The following is a description of a gene set: Human Gene Set: FAN_EMBRYONIC_CTX_BRAIN_ENDOTHELIAL_2 from publication Fan X, Dong J, Zhong S, Wei Y, Wu Q, Yan L, Yong J, Sun L, Wang X, Zhao Y, Wang W, Yan J, Wang X, Qiao J, Tang F (PMID 29867213) studied in species Homo sapiens, and this is the list of marker genes: BCHE, PGF, CCDC80, COL9A1, CCDC3, TJP1, PTH1R, FOXF2, C12orf57, GNG11, HEY2, PDLIM2, PARD3, ITPR1, ECM2, FBLN1, TFPI, CPE (carboxypeptidase E), EFEMP2, SLC12A2, TNFRSF21, TBX2, DCN, SEPTIN4, SLC20A2, SPARC, SGPL1, TAGLN2, GRM3, GALNT18, NR2F2, CDC42BPA (NCBI Gene Id 9876), PDE8B (NCBI Gene Id 8622, phosphodiesterase 8B), ANXA2, ADGRD1, PDLIM1, DGKH, LHFPL6, PTPRK, SEMA5A, SPRY1, KCNE4, CYTOR, CYTH3, SMTN, CNN3, TCEAL9, LGALS1, COX7A1, COL1A2, LURAP1L, ITIH5, PPFIBP2, ST3GAL5, AKAP12, F2R, ADORA2B, DMD, PCDH18, CAVIN3, ITSN1, LAMA4, CPPED1, GPM6B, GNG12, PDE7B, PPP1R14A, VCL, COL6A2, FERMT2, PLCE1, FRZB, TPM2, NFATC4, AMOTL1, CD151, PKIG, ARHGAP42 (NCBI Gene Id 83935), EPN2, EHD2, MAGED2, SLC12A7, PDE8A, COX7B, ITGB1, TBXA2R, CSPG4, NT5DC2, HEYL, PTEN, ATP5F1D, GUCY1A2, PARVA, SPON2, NID1, ZYX, DPY19L2, SEPTIN7, VAMP5, FN1, TRIB2, TAGLN, GGT1, LGALS3BP, OLFML2A, CDH6, COL5A2, HIGD1B, SMOC2, TGFB1I1, VSTM4, TNFAIP8L1, NDUFA4L2, ECE1, P2RY14, MCAM, CTNNBL1, MYOF, FXYD6, MAP1LC3A, FOXS1, IGFBP7, TNS1, RASL12, MYH9, SLC6A1, ADA, ANGPTL4, KANK2, AEBP1, CALD1, HES1, FAM162B, EMP2, ATP1B2, RHOC, LAMC1, TESC, COL4A2 (collagen type IV alpha 2 chain), ACTN1, UNC5B, PDZD2, ABCC9, BGN, PPP1R12A, CSAG1, KCNJ8, PLAC9, ITGA11, EBF1, SH2D3C, MDK, AGRN, PID1, PTN, ISYNA1, ARHGEF17, SELENOM, NID2, NOTCH3, JAK1, CD9, MYO1B, CFH, PLOD1, PAPSS2, SNRK, RFTN1, AASS, MPRIP, CRIP1, MYO6, COL4A1, TNKS1BP1, GGT5, HCFC1R1, TMEM74B, PLEKHA5, INPP4B, NODAL, APOD, EPB41L1, LUM, PLS3, VIM (vimentin), MAP3K20 (NCBI Gene Id 51784), MYLK, NHERF1, DENND2B, EPAS1, NTM, MYL9, COL6A1, LAMB1, LAMA2, ANPEP, ITGA1, RERGL, GPRC5C, FAM20A, SASH1, DOCK6, AMOTL2, SPARCL1, LRRC32, CCR10, BMP1, PTK2, SLC38A11, LAMB2 (NCBI Gene Id 3913), LAMC3, LIMA1, ZEB1, PLXDC1, SLC6A12, PDE5A, CD248, GJC1, CLEC11A, GOLIM4, FLNA, FARP1, ADAM33, ARHGAP29, LMNA, GUCY1A1, PDLIM7, CDC42EP1, PHACTR2, TPM4, S1PR3, TRPC6, PTGDR2, RBMS3, TSPAN12, COL3A1, CRIP2, ATP1A2, C11orf96, ZIC1, RBP1, LZTS1, PMP22, COL18A1, SNHG18, HES4, PDGFRB, PELO, TIMP3, PRELP, MGLL, UACA, CYC1, THY1, TBX18, FRMD6, ARHGEF12, EDNRA, NR2F1, RAPGEF4, PRKG1, IFITM3, HTRA3, SERPINH1 (NCBI Gene Id 89588), ADAM12, LDHB (NCBI Gene Id 3945), GPER1, GMDS, COLEC12, EPS8, ITGA4, SYNE2, CA4, SEPTIN11 (NCBI Gene Id 55752), TIMP1, AKIRIN1 (akirin 1), CFAP20, ECM1, PXDN, RNF24, GJA4, ILK, STARD13, ANXA6, PCOLCE, RGS5, SYTL2, CCDC102B, IFITM1, AK1, SLC43A3, PLAGL1, SNAI2, CTTN, GUCY1B1, SGCE (sarcoglycan epsilon), TMEM204, DLC1, SERPING1, ARHGAP10, MFGE8, CDH11, FSTL1 (follistatin like 1)